The following is a description of a gene set: The chemical reactions and pathways involving allantoin, (2,5-dioxo-4-imidazolidinyl)urea, an intermediate or end product of purine catabolism. Human Gene Set: GOBP_ALLANTOIN_METABOLIC_PROCESS studied in species Homo sapiens, and this is the list of marker genes: XDH, DNPH1, URAD, NT5C2, ADA, NT5C1A, GDA, PNP, ALLC, NT5C